The following is a description of a gene set: Human Gene Set: GOBP_REGULATION_OF_DNA_BIOSYNTHETIC_PROCESS Any process that modulates the frequency, rate or extent of DNA biosynthetic process. species: Homo sapiens, and this is the list of marker genes: PINX1, STN1, PTGES3, SH2B1, PRKD2, TENT4B, PCNA, ACD, ING4, TOM1L1, PARP3, RFC2, ATR, DSCC1, HNRNPD (heterogeneous nuclear ribonucleoprotein D), JADE3, DACH1, NAF1, CHTF8, HNRNPC, DUSP1, CCT6A, CTC1 (NCBI Gene Id 80169), CCT8, SMOC2, HNRNPU, HNRNPA1, RFC5, PDGFRB, DNAJC2, CTNNB1, TP53, KAT7, RFC3, NOX4, KCNK2, DKC1, ADIPOQ, NIBAN2, FBXO4, ANKRD1, CCT5 (NCBI Gene Id 22948), SMG6, TCP1, CDKN1A, CCT3, FGFR4, CCT4, PARN (poly(A)-specific ribonuclease), TNKS, EXOSC10, HSP90AA1, MEAF6, VEGFA, CCT2, ING5, PDGFB, RFC4, PIF1, ATM (ATM serine/threonine kinase), FGF2, HGF, GNL3L, HTR2A, TEN1, TERF2, TINF2, DCP2, TNKS2 (tankyrase 2), TFDP1, USP1, XRN1, PML, POT1, TNF, NPPC, JADE1, PDGFA, NAT10, POLG2, RGCC, CCT7, TERF1, WRAP53, CCNA2, JADE2, CHTF18, SMG5